The following is a description of a gene set: Mouse Gene Set: JIANG_AGING_HYPOTHALAMUS_DN A better understanding of the molecular effects of aging in the brain may help to reveal important aspects of organismal aging, as well as processes that lead to age-related brain dysfunction. In this study, we have examined differences in gene expression in the hypothalamus and cortex of young and aged mice by using high-density oligonucleotide arrays. A number of key genes involved in neuronal structure and signaling are differentially expressed in both the aged hypothalamus and cortex, including synaptotagmin I, cAMP-dependent protein kinase C beta, apolipoprotein E, protein phosphatase 2A, and prostaglandin D. Misregulation of these proteins may contribute to age-related memory deficits and neurodegenerative diseases. In addition, many proteases that play essential roles in regulating neuropeptide metabolism, amyloid precursor protein processing, and neuronal apoptosis are up-regulated in the aged brain and likely contribute significantly to brain aging. Finally, a subset of these genes whose expression is affected by aging are oppositely affected by exposure of mice to an enriched environment, suggesting that these genes may play important roles in learning and memory. from publication Jiang CH, Tsien JZ, Schultz PG, Hu Y (PMID 11172053) Down-regulated in the hypothalamus of aged (22 months) BALB/c mice, compared to young (2 months) controls species: Mus musculus, and this is the list of marker genes: Aco2, Syt1, Atp6ap1, Prkacb, Ubc, Dhx30, Gdi1, Cs, Gria1, Apoe, Cpe, Eprs1, Dlg4, Atp6v1e1, Dnaja2, Dnm1, Camk2g, Pld3, Atp1b2, Stip1, Kif5b, Epas1, Vsnl1, Canx, Vti1b, Ap2m1, Ache, Ddb1, Ptgds, Atp9a, Gpx4, Mgat2, Sars1, Fstl1, Rab18